Given this list of marker genes KCNJ11, ABCC9 (NCBI Gene Id 102724274), here is a description of the gene set: Reactome Pathway: Defective ABCC9 causes CMD10, ATFB12 and Cantu syndrome studied in species Homo sapiens part of: ABC transporter disorders ATP-binding cassette sub-family C member 9 (ABCC9) forms cardiac and smooth muscle-type KATP channels with ATP-sensitive inward rectifier potassium channel 11 (KCNJ11). KCNJ11 forms the channel pore while ABCC9 is required for activation and regulation. Inward rectifier potassium channels favor the flow of potassium into the cell rather than out of it. KATP channels open and close in response to intracellular changes in the ADP/ATP ratio, thereby linking the metabolic state of the cell to its membrane potential. Inhibition of KATP channel activity causes membrane depolarization and thereby activation of voltage-dependent Ca2+ channels, leading to Ca2+ influx and a rise in intracellular Ca2+ concentration. Correct maintenance of calcium balance is essential for the normal functioning of the heart.<br><br>Defects in ABCC9 can cause dilated cardiomyopathy 10 (CMD10: MIM:608569), a disorder characterised by ventricular dilation and impaired systolic function, resulting in congestive heart failure and arrhythmia. Defects in ABCC9 can also cause familial atrial fibrillation 12 (ATFB12; MIM:614050), characterised by disorganized atrial electrical activity and ineffective atrial contraction resulting in blood stasis in the atria and reduces ventricular filling. It can result in palpitations, syncope, thromboembolic stroke, and congestive heart failure. Defects in ABCC9 can also cause hypertrichotic osteochondrodysplasia (Cantu syndrome; MIM:239850), a rare disorder characterised by congenital hypertrichosis, neonatal macrosomia, a distinct osteochondrodysplasia and cardiomegaly (van Bon et al. 2012, Harakalova et al. 2012).